Given this list of marker genes ATCAY, PARK7, MIR21, SLC7A11, SLC7A7 (solute carrier family 7 member 7), CLN3, ACMSD, SIRT4, HNF4A, ATP2B4, NR1H4, FH, BHMT, here is a description of the gene set: Any process that modulates the frequency, rate or extent of the chemical reactions and pathways involving amino acids. Human Gene Set: GOBP_REGULATION_OF_AMINO_ACID_METABOLIC_PROCESS studied in species Homo sapiens